Given this list of marker genes DENND4A, SGSM3, DENND4C, DENND3, DENND1A (DENN domain containing 1A), MADD, DENND4B, here is a description of the gene set: Human Gene Set: GOBP_REGULATION_OF_RAB_PROTEIN_SIGNAL_TRANSDUCTION species: Homo sapiens Any process that modulates the frequency, rate or extent of Rab protein signal transduction.